The following is a description of a gene set: Any functional defect of the tricuspid valve. species: Homo sapiens Human Gene Set: HP_ABNORMAL_TRICUSPID_VALVE_PHYSIOLOGY Abnormal tricuspid valve physiology, and this is the list of marker genes: FKBP14, MTX2, PEX2, MYSM1, HCCS, CLIC2, TNNC2, ESAM, DNMT3A, CDH2 (cadherin 2), CSGALNACT1, FLNA, ABCC6, SCN5A, SCN4A, CITED2, ACTC1, COA6, TAFAZZIN, SLC31A1, DVL3, HADHB, SDHD, NDUFB11, ARL6, WDR37, MYCN, AGR2, MYH6, TBX5, ATP6AP1, HADHA, TNNI3, DLL4, TNNT2, IFT56, COX7B, ALPK3, KIF20A, FNIP1, LMOD2, PPP1R13L, PLD1, ADAMTSL2, ARSB, RAD21, PPP1CB, RNF2, RPS19 (ribosomal protein S19), ATP6V1E1, CHST14, MEGF8, ADAMTS19, ATRX, NCAPG2 (non-SMC condensin II complex subunit G2), FBN1, FLNC, CHST3, GATA6, NKX2-5, COX6B1 (cytochrome c oxidase subunit 6B1), VPS33A, ERI1, EFEMP2, COL1A2 (collagen type I alpha 2 chain), TLL1, TBX20, ALG9, TXNDC15, EXOSC5, MYH7 (NCBI Gene Id 8090), DOHH, MYPN, HEPHL1, SLC25A24, NEK1, RPL3L, NONO, GATA4, PRKAR1A